The following is a description of a gene set: Human Gene Set: GOMF_GLUCURONOSYL_N_ACETYLGALACTOSAMINYL_PROTEOGLYCAN_4_BETA_N_ACETYLGALACTOSAMINYLTRANSFERASE_ACTIVITY Catalysis of the reaction: D-glucuronyl-N-acetyl-1,3-beta-D-galactosaminylproteoglycan + UDP-N-acetylgalactosamine = N-acetyl-D-galactosaminyl-1,4-beta-D-glucuronyl-N-acetyl-1,3-beta-D-galactosaminylproteoglycan + UDP. studied in species Homo sapiens, and this is the list of marker genes: CHSY1, CHSY3 (chondroitin sulfate synthase 3), CHPF, CSGALNACT1, CHPF2, CSGALNACT2